The following is a description of a gene set: Human Gene Set: GSE34156_NOD2_LIGAND_VS_NOD2_AND_TLR1_TLR2_LIGAND_6H_TREATED_MONOCYTE_DN Genes down-regulated in monocytes (6h): muramyl dipeptide versus muramyl dipeptide and M. tuberculosis 19 kDa lipopeptide. species: Homo sapiens human blood monocytes were isolated, activated and harvested at several timepoints In this study, we identified genes that were differentially expressed in human monocytes activated with eiter NOD2L and/or TLR2/1L. from publication Schenk M, Krutzik SR, Sieling PA, Lee DJ, Teles RM, Ochoa MT, Komisopoulou E, Sarno EN, Rea TH, Graeber TG, Kim S, Cheng G, Modlin RL (PMID 22447076), and this is the list of marker genes: FGF6, ZPBP, ZNF398, LRIG1, GCM2, KLRG1, CAPRIN2 (NCBI Gene Id 84116), BPHL, SARDH, GPX2, FIGLA, COL5A1, REEP1, ARHGEF25, FBXO45, JARID2, IL36RN, ABCG1, GNB5, SYN2, PBDC1, EHHADH, CDX4, KRT4, PLA2R1, PMPCA, SMN1 (survival of motor neuron 1, telomeric), MATR3, CYP3A43, MT3, NCF2, RGS5, FBXW7, RCL1, MYH2, SERPINB2, HADH, RRAD, CYP3A7, CCDC28B, LETM1, TMEM131, BCHE, HOMER3, MOG, CMKLR1, NSUN2, DLGAP4, GTF3C2, CA5A, FAM98A, EPCAM, LGALS7, SH3YL1, SAMD4B, ASCL1, ARMC1, COQ5, BLK, SSTR4, PSMD1, GPHN, CDC26, TGFB1, FAM20C, RTKN, GPX1, MRPL55, GMCL1, TEX261, CHST2, EXOC8, GABRB3, GBX2, NAT2, SLC26A2, DSG2, TNFAIP8L1, SLC35G6, UBE2A, KCND2, EPAS1, ASS1, SLC12A3, GAD2, UTP3, NFYA, SORD, PC, DHX15, STK10, VIPR2, SERAC1, GFPT2, RPS6KA2 (ribosomal protein S6 kinase A2), MFF, FANCM, OR10J5, GLE1, THAP4, DLX3, MYL1, SOX6, SLC22A6, OMP, TGM3, DHCR24, MAD2L1BP, SLC25A45, UBE2E3, MSMB, TSPO2, DMPK, GABRB2, FBXO15, DAP3, SEMA4B, COPS7A (NCBI Gene Id 50813), FAM241A, IKZF1, CNTN1, TCF20, PYCR2, SERF1A, BCL2L1, CSNK2A2, GNAS-AS1, LENG8, GZMB, VPS37A, RNF181, MYO1C (NCBI Gene Id 4641), KIF9, KCNN4, YIPF3, PLEKHB2, IFI30, AMY2A, PDGFA, TARBP2, AIRE, OTUD7B, ATP5MF, TEN1, ZDHHC9, GCSH, OXT, CLEC4F, NEFH, FAM83H, KLHL21, ZNF703, SMYD2, PCYT2, RAB17, LTV1, HTR1D, HCN3, TENM1, THOC3, RPL39L, SCG2, HYCC2, DUSP2, MAPKAPK5, NIFK, XPNPEP1, KRT32, NCF1 (NCBI Gene Id 653844), UPP1, APOE, HAL, ORC5, RPL35, DCTN5, CKMT2, DGAT1, APLP1, ANKRD10, SRP9, ORMDL1, HGFAC, RAB3IL1, COX6B1, RCVRN, GCAT, CCDC115, MORC4, RING1, UTP18, PIK3CA, STK36, BHMT2, IL16, DDX51, CA8, HCK, PAH, HBA2, CLDN8